Given this list of marker genes OLFML3, PDP1, FGF9, ZFP36L2, ATP2B4, COL11A1 (NCBI Gene Id 317718), SOX11, MSTN, IGFBP3, TCF4, MOXD1, MYL11, PLK2, GLRX, here is a description of the gene set: species: Homo sapiens from publication Davicioni E, Finckenstein FG, Shahbazian V, Buckley JD, Triche TJ, Anderson MJ (PMID 16849537) Genes down-regulated in RMS cells (rhabdomyosarcoma) expressing PAX3 or PAX7 fusions with FOXO1 compared to the fusion negative cell lines. Human Gene Set: DAVICIONI_RHABDOMYOSARCOMA_PAX_FOXO1_FUSION_DN Alveolar rhabdomyosarcomas (ARMS) are aggressive soft-tissue sarcomas affecting children and young adults. Most ARMS tumors express the PAX3-FKHR or PAX7-FKHR (PAX-FKHR) fusion genes resulting from the t(2;13) or t(1;13) chromosomal translocations, respectively. However, up to 25% of ARMS tumors are fusion negative, making it unclear whether ARMS represent a single disease or multiple clinical and biological entities with a common phenotype. To test to what extent PAX-FKHR determine class and behavior of ARMS, we used oligonucleotide microarray expression profiling on 139 primary rhabdomyosarcoma tumors and an in vitro model. We found that ARMS tumors expressing either PAX-FKHR gene share a common expression profile distinct from fusion-negative ARMS and from the other rhabdomyosarcoma variants. We also observed that PAX-FKHR expression above a minimum level is necessary for the detection of this expression profile. Using an ectopic PAX3-FKHR and PAX7-FKHR expression model, we identified an expression signature regulated by PAX-FKHR that is specific to PAX-FKHR-positive ARMS tumors. Data mining for functional annotations of signature genes suggested a role for PAX-FKHR in regulating ARMS proliferation and differentiation. Cox regression modeling identified a subset of genes within the PAX-FKHR expression signature that segregated ARMS patients into three risk groups with 5-year overall survival estimates of 7%, 48%, and 93%. These prognostic classes were independent of conventional clinical risk factors. Our results show that PAX-FKHR dictate a specific expression signature that helps define the molecular phenotype of PAX-FKHR-positive ARMS tumors and, because it is linked with disease outcome in ARMS patients, determine tumor behavior.